The following is a description of a gene set: Reactome Pathway: Regulation of CDH1 posttranslational processing and trafficking to plasma membrane CDH1 (also known as E-cadherin, epithelial cadherin, Cadherin-1, CADH1, or uvomorulin) is synthesized as a precursor protein of ~140 kDa. The N-terminal signal peptide (amino acid residues 1-22) is removed in the endoplasmic reticulum (ER), while the proprotein region (amino acid residues 23-154) of CDH1 is cleaved in the trans-Golgi network, resulting in a protein of ~120 kDa. While proteolytic cleavage is not necessary for CDH1 presentation at the plasma membrane, it is necessary for the establishment of homotypic interactions at adhesion junctions. The proprotein sequence of CDH1 is predominantly removed by FURIN, but other proprotein convertases are also involved. Like other plasma membrane proteins, CDH1 undergoes glycosylation on multiple amino acid residues. Four glycosylated asparagines in CDH1 conform with the glycosylation sequon Asn-X-Thr/Ser which is glycosylated in the endoplasmic reticulum (ER) through transfer of the preassembled, high-mannose oligosaccharide, Glu3Man9GlucNAc2 glycan, from a dolichyl-pyrophosphate carrier by the oligosaccharyltransferase (OST) complex. N-glycosylation of CDH1 on four asparagine residues, and N637 in particular, is required for proper folding and translocation of CDH1 to Golgi for further processing. In Drosophila, the glucosyltransferase Xiantuan (also known as xit, a homologue of yeast ALG8), which encodes one of the enzymes involved in the addition of the terminal glucose residues to the Glu3Man9GlucNAc2 glycan precursor, is required for the proper glycosylation and intracellular distribution of E-cadherin. CDH1 also undergoes O-mannosylation in the ER, with TMTC3 as one of the implicated ER mannosyltransferases. CDH1 associates with beta-catenin (CTNNB1) during posttranslational processing in the ER. In the Golgi, CDH1 may undergo additional glycosylation catalyzed by GALNT3, which transfers O-GalNAc group to target proteins. During apoptosis, ER stress was reported to lead to O-glycosylation of both CTNNB1 and the CDH1 cytosolic tail, blocking exit of CDH1 from the ER, and reducing intercellular adhesion. Trafficking of CDH1 to the plasma membrane from Golgi is negatively regulated by RAB2A. Golgi membrane protein TMEM165 was also reported to negatively regulate CDH1 trafficking to the plasma membrane by affecting CDH1 glycosylation. CDH1 glycosylation was found to be altered in cancer, which can have an effect on CTNNB1 signaling. Cell type-specific processing of CDH1 has also been reported. Trafficking of CDH1 to the cell surface can be regulated in a cell confluency-dependent manner, so that subconfluent cells present less CDH1 on their surface. Glycosylation of CDH1 was also reported to differ between confluent and subconfluent cells. species: Homo sapiens part of: Regulation of CDH1 Expression and Function, and this is the list of marker genes: CDH1, CSNK2A3, OSTC (NCBI Gene Id 58505), PCSK6, CTNNB1, DDOST (dolichyl-diphosphooligosaccharide--protein glycosyltransferase non-catalytic subunit), CSNK2A2, POMT2, PRKCSH, POMT1, SEC11C, MOGS, ARHGAP32, PIP5K1C, CSNK2A1, SPCS3, RPN1, PCSK7, CANX, SPCS2, STT3A, JUP, RPN2, GANAB, SPCS1, FURIN, OST4, DAD1, TMEM258, ANK3, CSNK2B, SEC11A